Given this list of marker genes Upp2, Nt5c, Upp1, Dpys, Cda (NCBI Gene Id 72269), Nt5c3, Upb1, Dpyd, here is a description of the gene set: species: Mus musculus The chemical reactions and pathways involving dCMP, deoxycytidine monophosphate. Mouse Gene Set: GOBP_DCMP_METABOLIC_PROCESS